Given this list of marker genes PSMC3, MT-ND4L, SETX, MT-CYB, B2M, NAGS, GCLC, MT-ATP6, PEX7, CD59, SLC12A6, PEX12, NF2, TTR, MT-ND6, MT-ND4, PRPS1, GSN, PMM2, MT-ND2, NGLY1, DARS2, ARL6IP1, HYCC1, SNAP29, OPA1, RPIA (NCBI Gene Id 22934), ALAD, MPV17, BCKDK, PSAP, ERCC6, LDB3, ERCC8, SEPTIN9, ATXN10, SPTBN1, DGUOK, ABCD1, EDNRB, MT-CO3, MT-ND1, UQCRC1, TMEM70, HLA-DQB1, AIFM1 (NCBI Gene Id 9131), MYD88, CYP7B1, HLA-DQA1, ATP7B, PDYN, MYOT, DHH, COQ7, GRM1, NF1, TBC1D24, COQ4, MTRFR, PEX11B, LITAF, SYNE1, DMXL2, FUCA1, MT-ND5, here is a description of the gene set: Polyneuropathy A generalized disorder of peripheral nerves. studied in species Homo sapiens Human Gene Set: HP_POLYNEUROPATHY